The following is a description of a gene set: species: Homo sapiens Any process that results in a change in state or activity of a cell (in terms of movement, secretion, enzyme production, gene expression, etc.) as a result of a retinoic acid stimulus. Human Gene Set: GOBP_CELLULAR_RESPONSE_TO_RETINOIC_ACID, and this is the list of marker genes: OSR1, CYP26B1, CREB1, SNRNP70, EPHA3, ALDH1A2, PHC1, NDUFA13, PTK2B, WNT7B, MEIOSIN, GSK3B, RORB, TNF (tumor necrosis factor), WNT2, RXRB, YES1, HAND2, LYN, RET, LEP, WNT3A, STRA8 (stimulated by retinoic acid 8), AQP1, SLC6A4, FGFR2, LTK, PAX2, NTRK3, WNT6, YAP1, WNT9A, MYB, ATM, WNT5B, SERPINF1, RARG, DRD2, TEAD2, WNT3, HDAC2, BRINP1, ANKK1, WNT10B, SOX9, TESC, FZD7, PTK7, ABCA1, TNC, COL1A1, KLF4, WNT11, BRINP2, HTRA2, WNT8B, ZNF35, HOXA2, ABL2, TWF2, WNT9B, WNT5A, BRINP3, TBX1, FZD4, FZD10, PTK6, RARA, SNW1